The following is a description of a gene set: An anomalous response to the glucagon stimulation test, which like the insulin tolerance test (ITT) stimulates the release of both adrenocorticotropic hormone (ACTH) and growth hormone (GH). Abnormal response to glucagon stimulation test species: Homo sapiens Human Gene Set: HP_ABNORMAL_RESPONSE_TO_GLUCAGON_STIMULATION_TEST, and this is the list of marker genes: UCP2, KCNJ11, ABCC8, HNF1A, MED12